The following is a description of a gene set: The mitotic cell cycle phase transition whose occurrence commits the cell from the G0 quiescent state to the G1 phase. Under certain conditions, cells exit the cell cycle during G1 and remain in the G0 state as nongrowing, non-dividing (quiescent) cells. Appropriate stimulation of such cells induces them to return to G1 and resume growth and division. The G0 to G1 transition is accompanied by many changes in the program of gene expression. studied in species Mus musculus Mouse Gene Set: GOBP_G0_TO_G1_TRANSITION, and this is the list of marker genes: Bcl7b, Kcnn4, Smarcb1, Sox15, Dpf3, Cdk3, Dab2ip, Lin37, Smarca2, Cdkn2b, Smarce1, Arid1a, Smarcd2, Phf10, Smarcc2, Dpf1, Dpf2, Bcl7c, Rrm2b, Actb, H2-M3, Smarcc1, Ppp2r5b, Orc1, Rhno1, Ccn2, Arid2, Smarcd3, Znhit1, Pbrm1, Med1, Smarcd1 (NCBI Gene Id 83797), Smarca4, Actl6a, Brd7, Rrm1, Foxo4, Bcl7a, Actl6b, Ccnc